The following is a description of a gene set: studied in species Homo sapiens Human Gene Set: HP_HYPERKERATOSIS Hyperkeratosis is thickening of the epidermis involving the outer layer of the skin, the stratum corneum, which is composed of large, polyhedral, plate-like envelopes filled with keratin which are the dead cells that have migrated up from the stratum granulosum. Hyperkeratosis, and this is the list of marker genes: LAMC2, KANSL1 (NCBI Gene Id 791085), PERP, DSC2, XPC, COL17A1, EXPH5 (NCBI Gene Id 23086), PPP1R13L, SHOC2, SERPINB7, DSG4, IL17F, ABCA12, NAGA, FUCA1, USF3, LAMB3, COL6A2, FLG, AAAS, CDSN (corneodesmosin), LIPN, FLT4 (NCBI Gene Id 7909), KLLN, GJB4, MVK, KANK2, AP1S1, TERT, DDB2, HPGD, ADAMTS2, KRT16, SULT2B1, JUP, PARN, KRT6B, TRPM4, PLOD1, WNT10A, NEU1, AP1B1, AAGAB, CST6, FERMT1, MDFIC (NCBI Gene Id 29969), TRAPPC11, ANAPC1, CARD14, KRT2, KDF1, KRT13, FKBP14, PSENEN, DKC1, DIP2B, LSS, SERPINB8, PNPLA1, TAT, CSTA, RNU4ATAC, TRPS1 (transcriptional repressor GATA binding 1), DST, STS, FIG4, CD28, RECQL4, PMVK, SOX18, TYMS (NCBI Gene Id 7298), MAD1L1, NPM1, IL17RA, DSP, CLEC7A, KLHL24 (kelch like family member 24), CAST, POMP, TGM1, CTC1, LRP1 (NCBI Gene Id 4035), NOP10, KRT85, KRT17, EPHB4, KRT1, BRAF, ERCC2, MTX2, VEGFC, SMARCAD1, TINF2, ANGPT2, VPS33B, SERPINA12, HLA-DRA, USB1, RBP4, KRT81, COL14A1, KRT9, ERCC4, XPA, TARS1, PIK3CA, NHP2, KRT74, TRAF3IP2, COL6A1, ERCC3, RTEL1, SDHC, GJC2, ASPRV1, ADAM10, GJB3, SRD5A3, LZTR1, SPTLC1, ITGB4, ELOVL4, TUFT1, NIPAL4, MBTPS2, KRT5, KRT10, SPTLC2, DOLK, KRT83 (NCBI Gene Id 652010), LAMA3, NLRP1, WRAP53, PTEN, ST14, POLA1, COL7A1, SDR9C7, ELMO2, INSR, TERC, ATP2C1, GBA1, CERS3, SEC23B, DSG1, IKBKG, DNAJC21, ALOX12B, KRT6C, HLA-B, PLEC, RHBDF2, CTLA4, ATP2A2, PIGL, ELOVL1, SLURP1, GMPPA, GRHL2, ALOXE3, ATL1, ENPP1, PPOX, ZMPSTE24, TP63, TRPV3, FGFR2, SNAP29, CTSC, MPDU1, KDSR, RSPO1 (NCBI Gene Id 284654), ATL3, NSDHL, KRAS, ZNF750, HDAC6, MAP2K2, GJB6, KRT14, PKP1, LORICRIN, MCOLN1, COL12A1, HRAS, ERCC5, KRT6A, ALDH3A2 (NCBI Gene Id 224), ERMARD, ECM1, CDH3, DDR2, POFUT1, POGLUT1, IL1RN, DSC3, PDGFRB, SLC27A4, GLA, SREBF1, MAP2K1, AQP5, SDHB, RIGI, KLK11, TNFRSF1B, IL17RC, SDHD, GJB2, SASH1, KRT86, NECTIN1, GLS, TYR, PEPD, PIEZO1, COG6, WRN, KITLG, TRIP4, NECTIN4, RIT1, ZC4H2, MMP1, COL6A3 (NCBI Gene Id 1293), LMNA (lamin A/C), SLCO2A1, CFTR, CYP4F22, AKT1, GJA1